The following is a description of a gene set: Abnormal blood test results measuring creatine kinase (CK), CK-MB, troponin (TROPI), myoglobin, and/or cardiac enzymes. Abnormal cardiac biomarker test Human Gene Set: HP_ABNORMAL_CARDIAC_BIOMARKER_TEST species: Homo sapiens, and this is the list of marker genes: HMGCR, PSMB9, SVIL, NPPA, TTR, DSG2, SCN5A